Given this list of marker genes RAB6B, ADAMTS9, CHST2, CREB5 (NCBI Gene Id 9586), ZNF385B, SORCS1, PATZ1, ASXL2, ARGLU1, TMEM154, COL1A1, GTDC1, SOCS4, RTEL1, AGO1, PAQR8, HCFC1, ZER1, CYGB, POU6F1, KLK10, GLIPR2, PABIR1, VASN (NCBI Gene Id 337957), BCL11B, ATP6V1C1, PITPNC1, EGFLAM, WDR48, CNOT3, ERG, TM9SF4, IFIT1, SYT1, HNRNPF, ZEB2, S100B, SMG7, SERPINB5 (NCBI Gene Id 5268), POU3F4, PRP4K, BAIAP2, TNR, BNIP3L, PIK3C2B, FAM131B, LDLRAD2, GPM6B, SPRED1, TMEM81, SPTB, CLUH, RNF214, SATB2, HSPD1, DUSP5, SLITRK3, VASP, ARL6IP1, OGT, B4GALT7, RBFOX1 (NCBI Gene Id 54715), EN2, YWHAZ, OSBP2, CBL, ANTXR2, CREBRF, CSNK1G1, CERKL, ASIC1, PPP1R14C, SRSF2, PPA2, DIAPH1, MAP9, MCAM, PDE4A, ERMP1, SLITRK1, UBE2V1, KMT5A, DCTN4, SDK1 (NCBI Gene Id 221935), SYCP2L, EFNB3, HNRNPUL1, RILPL1, MYO3B, TCF12 (transcription factor 12), CCPG1, NCAM1, MTUS1, NXF1, HERC6, TMEM70, TNRC6B (trinucleotide repeat containing adaptor 6B), XBP1, ZNF607 (zinc finger protein 607), KHNYN (NCBI Gene Id 23351), ISX, DCAF7, SLC7A1, WAPL, COL18A1, UBE2L3, RIMS2, IER5, PEDS1-UBE2V1, PCNP, GFRA2, CCDC184, HEPN1, GADD45A, MACROH2A1, ASTN1, STAT4, TRAF3, MARCHF6, PLCB1, LIF, RUNX3, WEE1, here is a description of the gene set: Human Gene Set: AGGAAGC_MIR5163P Genes having at least one occurence of the motif AGGAAGC in their 3' untranslated region. The motif represents putative target (that is, seed match) of human mature miRNA hsa-miR-516-3p (v7.1 miRBase). species: Homo sapiens